The following is a description of a gene set: species: Homo sapiens Human Gene Set: chr1q43, and this is the list of marker genes: RPL23AP20, RFKP1, RN7SKP12, RNU6-725P, LGALS8, HNRNPA1P42, LGALS8-AS1, LINC01139, MTR, RPS7P5, CHRM3-AS1, TUBB8P6, RPL6P3, ENO1P1, SDCCAG8, RPL36P6, CHRM3-AS2, RPL10AP5, ACTN2, RPSAP21, FCF1P7, BECN2, RNU6-747P, RGS7, SEPTIN14P21, MTCYBP15, RYR2, LINC01347, WDR64, RPL35P1, RNU5F-8P, CHRM3, FH, MIR4677 (NCBI Gene Id 100616343), KMO, CFL1P4 (cofilin 1 pseudogene 4), KRT18P32, ZP4 (NCBI Gene Id 57829), CICP21, CEP170, ENSG00000259776, MIR4428, CHML, ENSG00000286496, MT1HL1, MTND5P18, GREM2 (NCBI Gene Id 64388), THAP12P8, ENSG00000237250, ADH5P3, MAP1LC3C, MIR3123, YWHAQP9, PLD5, MIPEPP2, ENSG00000234464, HEATR1, RN7SKP195, OPN3, MTCO1P38, EXO1, FMN2, MTND6P15 (NCBI Gene Id 106478949), RSL24D1P4